The following is a description of a gene set: Mouse Gene Set: GOCC_SMOOTH_ENDOPLASMIC_RETICULUM_MEMBRANE The lipid bilayer surrounding the smooth endoplasmic reticulum. studied in species Mus musculus, and this is the list of marker genes: Aldob, Aqp8, Svip, Itpr1, Ttyh1, Stx17, Ftcd, Napepld